Given this list of marker genes Rae1, Aaas, Nup155, Nup93, Nup54, Nup85, Nup205, Ndc1, Nup58, Ccnb1, Nup210, Cdk1, Seh1l, Nup133, Nup42, here is a description of the gene set: species: Mus musculus This event has been computationally inferred from an event that has been demonstrated in another species.<p>The inference is based on the homology mapping from PANTHER. Briefly, reactions for which all involved PhysicalEntities (in input, output and catalyst) have a mapped orthologue/paralogue (for complexes at least 75% of components must have a mapping) are inferred to the other species. electronically inferred by orthology from the curated human pathway Reactome Pathway: Nuclear Pore Complex (NPC) Disassembly part of: Nuclear Envelope Breakdown